Given this list of marker genes MDM2, MAPK14, ATM, INO80, MAP3K20, PARTICL, CHEK2, BABAM2, CLOCK, BLM, SFRP2, SWI5 (NCBI Gene Id 375757), RAD1, TREX1, HSF1, SFRP1, NET1, SNAI2, RAD51AP1, BRCC3 (BRCA1/BRCA2-containing complex subunit 3), NUCKS1, XRCC6 (X-ray repair cross complementing 6), TP53BP1, RPL26, GADD45A, FBXO4, WRN, EEF1D, BCL2L1, EGR1, SPIDR, BBC3, ZMPSTE24, CCND2, XRCC5, ITGB6, CRYAB, INTS7, RHOB, HRAS, BARD1, MIR21, YAP1, ELK1, NIPBL (NCBI Gene Id 25836), RAD9A, SIRT1, BRCA1, RAD9B, TP53, GTF2H5, ECT2, LIG4, TGFB1, GRB2, TNF, TSPYL5, TNKS1BP1, RAD51, LCN2, CYBA, PRAP1, TANK, FIGNL1, TLK2, TMEM109, HUS1 (HUS1 checkpoint clamp component), ATR, GATA3, KDM1A, BRCA2, IFI16, KDM4D, CDKN1A, RHNO1, here is a description of the gene set: Any process that results in a change in state or activity of a cell (in terms of movement, secretion, enzyme production, gene expression, etc.) as a result of a ionizing radiation stimulus. Ionizing radiation is radiation with sufficient energy to remove electrons from atoms and may arise from spontaneous decay of unstable isotopes, resulting in alpha and beta particles and gamma rays. Ionizing radiation also includes X-rays. Human Gene Set: GOBP_CELLULAR_RESPONSE_TO_IONIZING_RADIATION species: Homo sapiens